The following is a description of a gene set: Mouse Gene Set: GOMF_TRACE_AMINE_RECEPTOR_ACTIVITY studied in species Mus musculus Combining with a trace amine to initiate a change in cell activity. Trace amines are biogenic amines that are synthesized from aromatic amino acids and are substrates for monoamine oxidase, and are therefore detectable only at trace levels in mammals., and this is the list of marker genes: Taar8a, Taar7a, Taar9, Taar3, Taar6, Taar7f, Taar8c, Taar1, Taar7e (trace amine-associated receptor 7E), Taar4, Taar7d, Taar7b, Taar5, Taar8b, Taar2